Given this list of marker genes HADHB, AP5Z1, RPTN, PRG3, SCN11A, AXL, NR1H3 (NCBI Gene Id 113429), UBR2, SAMD4A (sterile alpha motif domain containing 4A), RAI2, ZNF608, TECPR2, CPT1A, PLIN2, FBXO32, PRG2, CDK7, TTYH2, TMEM26, ANXA2, BCAP31, PTPN13, DSP, MGST2, MARVELD1, C16orf74, SEMA6D, PHAX, UBXN4, CRABP2, HERPUD1, DDT, SPIC, SELENOK, HOXD10, NLN, HEY1, ADCY3, ABHD12, SHISA9, ADAP2, C11orf54, ACTRT1, AFMID, SIRPB1, TVP23B, TGFBR2, STOM, WDR17, VAMP4, IL16, ATP6V0A1, PLXDC2, ZC3H12A, MAPKBP1, CD38, RBM39, CEP112, ANGPTL4, NOS2, PPP1CA, ABCD2, SHTN1, SLC9A6, OSBPL7, TAF7, CXCL14, MAFB, SNX10, F7, CEP15, GSTT1, C6orf141 (NCBI Gene Id 135398), ERCC6, ZBTB7A, MAMLD1, GLDC, HTR6, MAOA, CIMIP7, HNRNPUL1, TMEM65, CD82, CHD4, GNAI1, MYO1A, CNOT4, SORT1 (sortilin 1), IL33 (interleukin 33), LIMS4, REM1, FSD2, SDC4, KLHL9, DAG1, UGT2B17, ZNF446, UNC119, HADHA, LAMA3, LIMS2, ABHD3, EVPL (envoplakin), MAN1C1, ETHE1, USP40, CD36, PECR, S100A9, GSTO1, SASH3, SERPINB6, KRTAP4-11, SIGLEC1, HINT3, CDK17 (cyclin dependent kinase 17), MGLL, RASL12, CASP8, CAMP, PDPK1, VIPR1, ARID5B, SLCO2B1, TNFRSF21, MPC2, LPCAT3, MALAT1, GRK3 (NCBI Gene Id 157), ZBTB5, VPREB1, CHAMP1, VSIG8, DBI, HAGH, GPM6A, SNX27, ACAA2, ALDH1A2 (aldehyde dehydrogenase 1 family member A2), ZNF43, SBNO2, HEBP1, ZNF462, PPP2R5E, CCR1, TWIST1, CILP, IL18, ZMIZ1, WNK3 (NCBI Gene Id 65267), HMOX2, SOD3 (NCBI Gene Id 6649), CCNT2, PTGIS, CARD11, M6PR, ANGPTL3, RGL3, FAM168B, TMEM141 (NCBI Gene Id 85014), FAM184B, SLC37A2, EBP, GLUL, TSPAN33, SRI, PPT2 (palmitoyl-protein thioesterase 2), CYP11B2, CASZ1, STARD5, ELL, PEX11A, SLC9A1, ABI3, FMO1, EREG, ZBTB38, SLC25A51, BLTP3B, IQSEC1, KLF7, S100A8, GPX1, RPS11, PSEN2, GPCPD1, CD200, STAB2, PDGFC, TTC39B, RAMP1, RAB29, ASPA, TALDO1, MARCHF6, PON2, ENPP1, CTNNB1, SON (NCBI Gene Id 84155), ST6GALNAC2, here is a description of the gene set: species: Homo sapiens Genes up-regulated in bone marrow-derived macrophages with IL10 knockout and 45 min of stimulation by: LPS versus IL6 and LPS. Human Gene Set: GSE5589_LPS_AND_IL10_VS_LPS_AND_IL6_STIM_IL10_KO_MACROPHAGE_45MIN_UP from publication El Kasmi KC, Holst J, Coffre M, Mielke L, de Pauw A, Lhocine N, Smith AM, Rutschman R, Kaushal D, Shen Y, Suda T, Donnelly RP, Myers MG Jr, Alexander W, Vignali DA, Watowich SS, Ernst M, Hilton DJ, Murray PJ (PMID 17114459) IL-10 or IL-6 stimulation of control 129xC57BL/6 murine bone marrow derived macrophages in the presence of LPS. We used microarrays to detail the global programme of gene expression changes in response to IL-6 or IL-10 stimulation in the presence of lipopolysaccharide. BMDMs were isolated from control, IL-6-/-, and IL-10-/- mice on a 129XBL/6 mixed background mice and differentiated in the presence of CSF-1 for 6-7 days. Cells were scraped and plated in 6 well plates at 2x10e6/well. Cells were washed with complete DMEM and rested for 1-2 hr before stimulation with combinations of IL-10 (10 ng/ml), IL-6 (2 ng/ml) or LPS (100 ng/ml) for 45 min or 180 mins. Complete biological replicates were performed.